Given this list of marker genes SIN3A, ZC3H12A, TRIM44, ILRUN, TRIM38, PQBP1, ZMPSTE24, CD37, IFNLR1, TNFAIP3, DTX3L, IRGM, ATG5, TOMM70, MICB, PYCARD, TRAF3IP1, PML, PARP9, IL12RB1, IL12B, IL27, MIR26B (NCBI Gene Id 407017), RNF216, TSPAN32, IL23A, ZDHHC1, RNF26, NT5C2, MAVS, SPN (sialophorin), ATG12, FOXP3, PPM1B, SELENOK, TRIM22, IL15, IL23R, IL1B, C1QBP, TRAF3, MUL1, USP17L2, LILRB1, RIGI, STAT1 (NCBI Gene Id 6772), TRIM6, TARBP2, HSP90AA1, ELMOD2, MMP12, CCDC92, CGAS, ITCH, APOBEC3F, HERC5, ZDHHC11, APOBEC3G, AIM2, PCBP2, CREB3, STING1, EIF2AK4, DHX9, FGL2, ERCC6, TRAF3IP2, here is a description of the gene set: Any process that modulates the frequency, rate or extent of the antiviral response of a cell or organism. species: Homo sapiens Human Gene Set: GOBP_REGULATION_OF_DEFENSE_RESPONSE_TO_VIRUS